The following is a description of a gene set: Translation factors studied in species Homo sapiens Human Gene Set: WP_TRANSLATION_FACTORS, and this is the list of marker genes: EIF2AK2, GSPT2 (NCBI Gene Id 83029), EIF3F (NCBI Gene Id 8665), EIF5B, EIF1AY, ETF1, EIF4A1, EIF4E, EIF2B2, EIF3A, EIF2B3, EIF2AK3, EIF2S2, EIF2S3, EIF3C, EIF3I, EIF2S1, EIF4G3, EIF2B1, EEF1A1, EIF1AX, EIF4A2 (eukaryotic translation initiation factor 4A2), EIF3J, EIF1, EIF3H, EIF3D, EEF2K, EIF3B, EIF4EBP3, EIF4EBP1, EIF4EBP2, EIF5A, CLUH, EIF2AK1, EEF2, EIF4B, EIF4H, EIF2B4, EIF3G, EIF5, PABPC1, EIF6, EIF2B5, PAIP1, EEF1B2, EEF1G, EEF1A2 (NCBI Gene Id 6669), EIF3E, EEF1D, EIF4G1